The following is a description of a gene set: The gene expression program underlying the specification of human cell types is of fundamental interest. The study authors generated human cell atlases of gene expression and chromatin accessibility in fetal tissues. For gene expression, the study authors applied three-level combinatorial indexing to >110 samples representing 15 organs, ultimately profiling ~4 million single cells. The study authors leveraged the literature and other atlases to identify and annotate hundreds of cell types and subtypes, both within and across tissues. Our analyses focused on organ-specific specializations of broadly distributed cell types (such as blood, endothelial, and epithelial), sites of fetal erythropoiesis (which notably included the adrenal gland), and integration with mouse developmental atlases (such as conserved specification of blood cells). These data represent a rich resource for the exploration of in vivo human gene expression in diverse tissues and cell types. Marker genes curated from the annotated cluster as represented in the Descartes Human Gene Expression During Development database. from publication Cao J, O'Day DR, Pliner HA, Kingsley PD, Deng M, Daza RM, Zager MA, Aldinger KA, Blecher-Gonen R, Zhang F, Spielmann M, Palis J, Doherty D, Steemers FJ, Glass IA, Trapnell C, Shendure J (PMID 33184181) studied in species Homo sapiens Human Gene Set: DESCARTES_FETAL_SPLEEN_STC2_TLX1_POSITIVE_CELLS, and this is the list of marker genes: EBF3, ATP1A3, FBXL16, HRK, PANTR1, PRR36, CAMK2N2, TRH, CLVS2, CPLX2, GABRG2